Given this list of marker genes HSD17B3, CACNA1H, LHB, HINT2, MED1, H6PD, BMP6, IFNG, CREB1, INSIG1, CYP3A4, SRD5A1, ACAA2, AKR1B15, SREBF2, AKR1C3, NPC1L1, GGCX, ASAH1, HSD17B6, ARMC5, HSD3B7, PRKACA (protein kinase cAMP-activated catalytic subunit alpha), ERG28, PRKG1, SNAI1, CYP27B1, MBTPS1, FGF1, FSHB (NCBI Gene Id 2488), EBP (NCBI Gene Id 139151), CES1, CGA, HSD3B1, GFI1, FDX1, PROX1, MIR33A, REST, NR5A1, CYP11A1, CYP2R1, FGF19, MBTPS2, SDR42E1, EGR1, CYP24A1, DHCR24, IGFBP7, TM7SF2, HMGCS1, ACBD3, NFKB1, CYP8B1, NR3C1, BMP2, CYP19A1, RDH8, ATP1A1, CRH, PRKAA1, SCAP, CYB5R3, G6PD, KPNB1, STARD4, CYP27A1, CYP17A1, NSDHL, FDXR, DHRS11, MAPK1, ABCG4, ARV1, HSD17B1, LBR, ABCG1, MIR96, LIPA, HSD17B12, HSD17B7, LSS, SQLE, FDFT1, PRKAA2, PMVK, SC5D, TSPO, STAR, CYP11B1, MVD, C7orf50, WNT4, BGLAP, PLPP6, LEP, MIR548P, SDR42E2, NR5A2, STARD3, CYB5R2, SCP2, ERLIN1, DGKQ, INHBA, MIR182, SIRT1, GNAI1, HSD3B2, HSD17B2 (hydroxysteroid 17-beta dehydrogenase 2), MIR342, CYP11B2 (NCBI Gene Id 1585), IDI2, SREBF1, NR0B1, LPCAT3, CYB5R1, HSD17B8, DKKL1, LHCGR, APOA1, INSIG2, NR1D1, CYP51A1, ADM, GPRC6A, ACLY, HMGCS2, MALRD1, MIR185, HMGCR, SNAI2, PAQR3, POR, AQP8, DKK3, FGFR4, QKI, MIR98, SRD5A3, CYP7A1, NR1H4, APOB, CYP3A7 (NCBI Gene Id 1551), DHH, PBX1, CLCN2, SERPINA6, DAB2, HSD17B11 (NCBI Gene Id 51170), SEC14L2, MIR30C1, CYP21A2, BMP5, CYP7B1, CH25H, PRKAG2, FDPS, ABCA2, APOE, ERLIN2 (NCBI Gene Id 140906), FAXDC2, DHCR7, MVK, AKR1B1, MSMO1, CYP1A1, TNF, PDE8B, GPR146, IDI1, SRD5A2, PRLR, DDX20, CFTR (NCBI Gene Id 1080), here is a description of the gene set: Human Gene Set: GOBP_STEROID_BIOSYNTHETIC_PROCESS The chemical reactions and pathways resulting in the formation of steroids, compounds with a 1,2,cyclopentanoperhydrophenanthrene nucleus; includes de novo formation and steroid interconversion by modification. species: Homo sapiens